The following is a description of a gene set: Spleen and lymph node dendritic cells have a differential capacity do induce and retain iTreg cells. Therefore we performed a comparative analysis of the dendritic cells derived from these two compartments to identify the responsible genes from publication Vitali C, Mingozzi F, Broggi A, Barresi S, Zolezzi F, Bayry J, Raimondi G, Zanoni I, Granucci F (PMID 22760781) Human Gene Set: GSE39022_LN_VS_SPLEEN_DC_UP species: Homo sapiens Genes up-regulated in dendritic cells from: lymph node versus spleen., and this is the list of marker genes: COL1A2, SLC43A3, MEIS1, CD22, AGPAT4, SLC35F5, MXD1, RUNX3, IGSF9B, UBL3, MARCO, KCNK6, PANX1, FEZ2, CCP110 (centriolar coiled-coil protein 110), PLXND1, UBXN8, PDCD6, LHX2, GPR160, GFAP, MANF, IQGAP1, FLOT1, NRIP3, NUDT21, CWC15, MCM5, SAMD1, PLIN3, ATP13A2, PTPN18, SLC22A8, RIOK1, DUBR, ANGPT1, IDI1 (NCBI Gene Id 3422), UPP1 (uridine phosphorylase 1), FSTL4, IFI30, PWWP2B, SPP1, VIM, HNRNPUL1, SATB1, NMI, ALOX12B, CISD1, IGHG1, EIF4EBP1, PSMA2, NFATC2, FAM216A, TMED8, ZBTB38, GAS2L3, TMEM50B, ACTG1, KRTAP20-2, TIRAP, TMEM40, NUP155, ACSL5, CCNYL1, TICRR, MNS1, EHD1, ASPDH, CCDC12, ZIK1, ATAD5, SPRYD3, TBC1D2, UBE2S, TTF2, NEURL1B, TMEM30A, SDK1, GSC, FANCM, PAQR4, NMNAT2, RAD18 (RAD18 E3 ubiquitin protein ligase), NPTX1, AUNIP, SCIN, CNIH2, KIF23, IL17RB, PRDM4, CHEK1, ARL13A, CCNF, HPRT1, FNIP2, HSCB, ESYT1, TXNL1, EXO1, COX17, EDARADD, MID1IP1, IL36A (interleukin 36 alpha), PGAM1, ORC1, AEBP2, AP2M1, UAP1, MFGE8 (NCBI Gene Id 54740), PADI2, ST14, CYB561D2, NIBAN2, B4GALT5, HPN, OSBPL3, TPSB2, MBD2, TLR6, PRR11, CHAF1B, AKIP1, TXNDC5, PRRC1, PNP, POLD2, WEE1, RELB, RAPGEF2, LRRC59, RBL2, MIS18A, MIR22HG, KPNA2, NELFCD, AIFM2, CELA1, PRDM1, ISY1, CDV3, TPI1, NFIC, TBCD, MUTYH, APOL6, IL18RAP, TGFB3, GAPDH, FOSL2, TIPIN, RNASE10, KNDC1, FKBP14, DPAGT1, SELENOS, PDIK1L, SORD, HS6ST2, TACC1, SFT2D3, RAPGEF3, CRIPT, NUP37, TUBA4A, IL4, PALB2, AP4M1, PHGDH, NCOA7, NALCN (NCBI Gene Id 93074), TSGA10, C2CD4C, CHMP4B, LGALS8, ATF5, ADCY5, CMPK2, MKX, TMBIM4, LHFPL6, MACIR, SLC7A10, SEMA4A, GINS1, CLEC12B (NCBI Gene Id 387837), SLC38A10, CDK6, IFT22, POLD1, FEN1, ELOF1, PGGHG, SUV39H1, DBF4, PTPN13, CSF1, DENND4C, FAM241B, HAUS1